Given this list of marker genes Abi2, Akap13, Limk1, Nme7 (NME/NM23 family member 7), Ankrd23, Cdc42ep1, Sptbn1, Magel2, Ccdc88a, Mef2c, Baiap2l2, Tmod1, Prkce, Nphs1, Mfn2, Ccl21d, Arhgef2, Met, Camsap2, Pfn1, Eml2, Diaph3, Fchsd2, F2rl1, Shank3, Kif21a, Dnai3, Ssh3, Pycard, Ppp1r9a, Arpin, Tmod3, Prkn, Mtor (NCBI Gene Id 80612), Eps8, Ckap5, Arf1, Actn2, Hspa1a, Ckap2, Flii, Rnh1, Rapgef3, Rhoc, Inppl1, Clu, Pde4dip, Synpo2, Chadl, Emilin1, Inpp5k, Cyrib, Cfl2, Ankrd53, Braf, Mid1, Cit, Slain1, Slc39a12, Cdc42ep4, Cx3cl1, Col6a1, Wnt4, Cdc42ep2, Fchsd1, Tmeff2, Arhgap18 (Rho GTPase activating protein 18), Wasf2, Tnxb, Capn1 (calpain 1), Ccl21e (NCBI Gene Id 100504239), Pik3r1, Nox4, Cryab, Lpar1, Hdac2, Nav3 (NCBI Gene Id 676640), Cotl1, Tgfb3, Ssh1, Fmn1, Snx9, Cib1, Washc2, Limch1, Specc1l, Aebp1, Ppm1e, Shroom2, Rhoa, Apc, Rhpn1, Rdx, Tmsb15b2, Prune1, Lima1, Cav1, Clec2i, Clasp2, Grb2, Clip3, Apoe, Cdc42ep3, Was, Mtss1, Arhgap6, Baiap2l1, Daam2, Togaram2, Arfgef1, Spef1, Tenm1, Ttc8, Prex1, Mid1ip1, Gda, Ep300, Trim54, Cyfip2, Alms1, Map1b (NCBI Gene Id 268696), Hdac6, Cav3, Arhgef10l, Lmod3, Arpc5l (NCBI Gene Id 99428), Plekhg2, Map3k1, Camsap1, Id1, Nf2, Pfn2, Xirp2, Wdr1, Synpo2l, Hdgfl3, Ptk2b, Rasa1, Mkks, Bmp10, Svil, Rgcc, Smad3, Pdxp, S100a10, Ctnna2, Gpr65, Tpx2, Coro1a, Vil1, Asap3, Fermt2, Tac1, Map1s, Dapk3, Arpc5, Cd47, Mapt, Coro1b, Bin1 (NCBI Gene Id 30948), Fhod1 (NCBI Gene Id 234686), Tsc1, Arhgap35, Prkcq, Icam1, Dmtn, Lmod1, Edn1, Vasp, Ccn2, Arl2, Ptger4, Sptb, Tbcd, Actg1, Psen1, Washc5, Efemp2, Myo1c, Naa80, Sh3bp1, Tgfbr1, Htr1a, Add3, Gmfg, Vill, Arhgef7, Stmn2, Aurkb, Brk1, Clip1, Gja1, Fkbp4, Twf2, Clasp1, Phldb2, Chrna7, Inpp5j, Scin (NCBI Gene Id 20259), Sgk1, Tjp1, Flna, Coro2b, Ppm1f, Eml4, Arhgef15, Arfip2, Drg1, Cdk5rap2, Pfdn4, Mapk8, Frmd7, Capzb, Ldlr (low density lipoprotein receptor), Add2, Avil, Sh3pxd2b, Kirrel1, Mapre3 (NCBI Gene Id 100732), Hspa1b, Esam, Capza1b, Fer, Map2, Washc1, Bbs4, Arhgap40, Nckap1l, Epha1, Wasf1, Numa1, Sema5a, Pick1, Sptan1, Dbnl, Arhgef10, Carmil3, Tmsb15l, Spast, Fes, Kank3, Tacr1, Ccdc88c, Apc2, Ccl21f, Serpinf2, Abl1, Hspa8, Pfdn1, Dbn1, Prkd1, Itgb1bp1, Togaram1, Tesk1, Myoc, Tmod2, Gas2l2, Atxn7, Myh9, Hax1, Wmp, Trim27, Dyrk1a, Map6d1, Carmil1, Map1a, C9orf72, Bmerb1, Ccl21b, Plek, Usp8, Cracd, Dlg1, Git1, Kank1, Apoa1, Arpc2, Pfn3, Add1, Twf1, Arap1, Ap1ar, Sorbs3, Sdc4, Colgalt1, Slit2, Pak2, Capza2 (capping actin protein of muscle Z-line subunit alpha 2), Plekhh2, Pecam1, S1pr1, Gas2l1, Smad4 (SMAD family member 4), Rps3, Ppfia1, Swap70, Psrc1, Stmn1, Washc3, Nrp1, Katnb1, Pik3ca, Tlr2, Mapre1, Capza3, Pfdn5, Wasf3 (WASP family, member 3), Slain2, Actr3, Gsn, Ccl24, Pxn, Wnt11 (wingless-type MMTV integration site family, member 11), App (amyloid beta precursor protein), Shank1, Hspg2, Tubb4a, Kank4, Tmsb4x, Dctn1, Fhod3, Tpm1, Csf3, Ccl26, Vbp1, Cdkn1b, Dstn, Capza1, Pak3, Rock2, Fgf13, Baiap2, Gba2 (NCBI Gene Id 230101), Pfn5, Ccl11 (NCBI Gene Id 20292), Pik3r2, Gm14137, Wdr47, F11r (NCBI Gene Id 226655), Nck2 (NCBI Gene Id 74592), Arfip1, Whamm, Lmod2, Mecp2, Evl, Alox15, Carmil2, Cgnl1, Rictor, Rp1, Cttn, Pfdn6, Arhgef5, Washc4, Hip1r, Bag4, Kank2, Pak1, Spta1, Capg, Snca, Arf6, Ttbk2, Mtpn, Cyfip1, Nckap1, Dlc1, Cfl1, Cdc42ep5, Ccl21a, Hcls1, Arhgap28, Tacstd2, Prox1, Pdlim4, Rac1, Kiss1r, Rb1, Camsap3, Rhpn2, Nck1, Taok1, Gmfb, Tmod4, Cdh5, Lats1, Cyria, Arpc3, Trem2, Cdc42, Pfdn2, Myadm, Bbof1, Akap9, Trpv4, Prkcd, Mylk3, Abitram, Rgs4, Eln, Ssh2, Gm28729, Arhgef18, Mlst8, Synpo, here is a description of the gene set: Mouse Gene Set: GOBP_REGULATION_OF_SUPRAMOLECULAR_FIBER_ORGANIZATION studied in species Mus musculus Any process that modulates the frequency, rate or extent of supramolecular fiber organization.